The following is a description of a gene set: Human Gene Set: HP_VENTRICULAR_FIBRILLATION Ventricular fibrillation species: Homo sapiens Uncontrolled contractions of muscles fibers in the left ventricle not producing contraction of the left ventricle. Ventricular fibrillation usually begins with a ventricular premature contraction and a short run of rapid ventricular tachycardia degenerating into uncoordinating ventricular fibrillations., and this is the list of marker genes: AKAP9, MYBPC3, CACNA1C, KCNE5, SLC4A3, ACTC1, DSP, TECRL, MYL2, SCN1B, KCNJ2, SCN2B, CACNA2D1, KCNE3, TNNC1, PRKAG2, KCNE2, SCN3B, RYR2, KCNH2, SLC12A3, KCND3, CACNB2, NDUFB11, SCNN1A, ACADVL, MYL3, TRDN, KCNJ18, DHCR7, KCNE1, SEMA3A, GABRA3, KCNJ8, CACNA1S, SCN10A, BAG5, CALM2, HCN4, GPD1L, CASQ2, TANGO2, CALM1, KCNQ1, GYG1, TRPM4, SCN5A, DPP6, PKP2 (NCBI Gene Id 93271), SLMAP, RANGRF (NCBI Gene Id 51536), CALM3, CLCNKB, ALG10B, SNTA1, ABCC9